Given this list of marker genes HPCAL4, PLEKHH3, RAB30, CAPNS1, NAT9, SCN5A, KCND1, ZNF436, MED25, PDAP1, RPL39, CTTNBP2NL, SEC24D, ARHGEF2, RPS6KA3 (NCBI Gene Id 6197), TREX1, GPR3, DHX40, JAK2, ABHD2, RPS6KA4, BRD2, RNF186, VIT, TGFBR2, ST6GALNAC5, RAB5A, SLC39A13, STAT6, RELA, AKAP1, TFE3, PA2G4, SLC25A23, SPRR1B, MMP7, PCDH9, FAM180A, NR1D1, RCAN2, PPP1R9B, COMMD10, S100A2, PADI3, PITPNC1, TMEM156, SGK3, MMP19, LINC03042, CHST1, TRAF3IP2, MAPK3, OMG, ESRRG, CLDN15, SH2D1B, AP2M1, ENO1, VEGFA, XPOT, EPHX4, TM4SF19, SV2A, TUBA4A, PTP4A1, DGKA, DLG4, GAPDH, TENT5A, YWHAB, AGPAT4, AP5B1, DES (NCBI Gene Id 497658), SLC4A11, PIP5K1A, MMP1, KRT17, ATP1B1, SH3RF1, SBSN, DDX17, CD244, AIG1, UBQLNL, KLK12, NECAB3, SAMD14, KCNK10, BMAL1, BUB3, PRPF38B, RIPK4, KLHL41, TRIM47, ENO3, HOXB4, DUSP14, AKR1B1, LORICRIN, MMP20, PRLHR, MPRIP, ANAPC10, MACF1, ZPBP2, ZNF362, CHMP4B, CIDEC, IGSF21, MAP7D1, KY, CRISP1, LRRC15, DYNC1LI1, ZNF277, ZHX3, ABCB6, PI15, MRPS23, SLC6A5, MSTN, C1orf210, NTN4, GABARAPL1 (GABA type A receptor associated protein like 1), DDR1, DIDO1, ZFYVE26, RELT (NCBI Gene Id 84957), C3AR1, STAT5B, MMP13, ADAMTS14, SEPTIN9, CSMD3, AMDHD2, NT5C1B, MED15, PFKFB3, KLF9, SEL1L3, ZBTB43, SMPX, NPPB, LYSMD2 (NCBI Gene Id 256586), SLC22A2 (NCBI Gene Id 6582), TIAL1, NDST4, CPNE1, RHOC, RTN3, NRXN3, CPSF7, FOSL1, SRPK2, ZNF516-DT, GJB3, RAB27B, ODF1, UBE2R2, AHI1, CAVIN1, MARK2, ADCY8, WDR81, DGKB, SSH2, CXCL14, KLHL7, NFE2L3, RUNDC3A, TBL1X, FGF13, LGI3, GIPC1, MYRF, CSF3, DSTN, KRT15, MMP3, TSSK6, RAB34 (NCBI Gene Id 83871), AP2A2, TLN2, SLC26A9, CCDC120 (coiled-coil domain containing 120), RIN2, HOXC10, NAPB, CDKN1A, FBXO30, KCNH2, MEF2C, HNRNPD, IGSF9, ATP6V0D2, CRYGS, GPR174, TAFA4, FADS3, WNT7B, CDKN2C, P2RX6, PPP1R3C, GGN, BNIP3, EEF1A1, JAZF1, THOC6, C2CD2L, ASPH, MIR22HG, TRIM8, SMARCA2, GLT8D2, LNX1, SLURP1 (secreted LY6/PLAUR domain containing 1), TTC1, IL7R (NCBI Gene Id 3575), IL21, CASKIN1 (NCBI Gene Id 57524), OSMR (oncostatin M receptor), MIR17HG, USP12, CHRM1, GTPBP2, COL7A1, SNCB, LINC01567, KRT8, LRRC8E, ENO2, C1orf21, VEZF1, PVALB, TMEM40, ATP6V1A, ACADVL, IQSEC1, PRKCG, METTL6, IPO11, MAP4, CHST9, TUBB4A, BEND6, PCDH17, DOK1, BTK, BDNF, SH3D21, ABCA2, ABI3, USP2, DCSTAMP, CST6, HS3ST2 (NCBI Gene Id 9956, heparan sulfate-glucosamine 3-sulfotransferase 2), SLC1A5, ARPP21, SGK1, EMP1, TGIF1, RHOG (NCBI Gene Id 391), YPEL5, PCSK1N, LRRFIP2, IL9, HSPB3, BMP2, PEX5, ZNF207, LNPEP, SOST, TOR4A, STARD13, PADI4, GPM6A, RTN1, MPV17, ARIH1, ISG20, TRIM25, PRKAG3, CDK14, PPARGC1A, BDKRB1, PRR7, NUDT11, PSMA1, CPNE8, NRXN1, ABHD4, RELL2, PHF23, PSTPIP1, FSIP2, UVRAG, VGF, MLEC, VAMP5, NDUFA13, RABGAP1L (NCBI Gene Id 9910), CSPG4, LAMA3, DTNB, SLC38A2, ARAP2, TPBG, FOXA1, KCNN4 (potassium calcium-activated channel subfamily N member 4), CREB5 (cAMP responsive element binding protein 5), CSN1S1, SLC35B1, CPA4, IVL, COL5A3, PPP2R2A, SFN, VEGFD, TOB1, ASXL1, PRDM1, HDAC3, CST7, RGS2, SLC10A2, SH3RF2, EPS8L3, FBXO44, STC1 (NCBI Gene Id 82914), MYH14 (NCBI Gene Id 79784), COL27A1, TGM7, DMKN, CHST4, TRIB1, GRIA1, WNT3, CA9, PTPRN, EBF2, AMY2B, VTCN1, KBTBD8, GPR141, NLGN3, LRRC32, ZNF385B, PROSER3, ABTB3, AK5, RBBP7 (NCBI Gene Id 5931), FGF9, ELK3, ADGRG1, NRAS, C22orf31, AQP5, TENM3-AS1, HMGA1 (high mobility group AT-hook 1), FAM81A, COQ8B, LMOD3, ELL, ONECUT2, ADRA1A, TAC1, CCDC14 (coiled-coil domain containing 14), ILDR2, DPYD, PIK3C2G, DSC2, LRRN3, LRRN4CL, VIL1, YWHAG, TNFRSF12A, EAF1, APOBR, SLC25A45, MARCHF1, SLC26A1, PAFAH1B1, SLITRK6, EDN3, PSMD12, GPR158 (G protein-coupled receptor 158), CACNA1A, RUNX1T1, CD68, CXCR5 (C-X-C motif chemokine receptor 5), CLDN4, PEA15, ADAP2, CLDN9 (claudin 9), ADAMTS6, PDE4D, GAB2, AGBL5, MYBPH, PERP, GNGT2, BDKRB2, USP3, HARBI1, PPP1R15A, AKT3, ZRSR2, SRSF2, GDNF, BLMH, KRT16, HNF1A, PSMD7, FOXN1, MECOM, PKNOX2, TSR1, CCDC141, DMPK, TMEM14B, PKN1, ASS1, SERPINB2, REEP4, IDS, FAM91A1, HILPDA, ARF1, REPS1, GASK1B, PPP2CA, DRP2, BBLN, VAPA, SLC16A6, FBXO24, MIDEAS, CIMAP2, CLDN16 (NCBI Gene Id 107986170), SLC6A14, LONRF3, EFNA1, PDZD9, MAMDC2, SLC38A6, SFR1, ADGRF2P, TCF12, CAMK4, CSRNP1, MDM2, LINC02694, CYFIP1, VAX1, TSKU, ARHGAP8, PLA2G4F, SNCG, SPATS2, TLL1, VCL, HDAC9, CALB2, GASAL1, DTNA, RNF44 (NCBI Gene Id 260352), TMEM50B, NEFH, TFF1, FLI1 (NCBI Gene Id 2313), PRSS36, STRN3, ATG13, PSMD1, AIF1L, ETV5, ZBTB41, ESR1, MYB, DNAJC5B, GPR87, PROCR, FABP4, LGALS7, MPP3, GTF2F2, CNOT6L, G0S2, KLHL40, BTG3, MASP1, WNT6, F3, KCNQ1DN, PRDM12, PLAU, KRT13, CNGB3 (cyclic nucleotide gated channel subunit beta 3), AEBP1, KDM5C, KRT25, APP, FST, XYLT1 (NCBI Gene Id 64131), MYL6B, PSMD4, MMP12, TRAPPC3, HSPB7, NCS1, SLC6A10P, POLD4, EML3, TAGLN2, UCN2, LENEP, CA7, AXIN2, HAUS1, EPB41L1, ZNFX1, PDE6H, PSMA5, KLHL13, S100A5, NCDN, SLC9A8, SH2D3A, RNF144B, ARHGAP32, C1orf220, CAPN12, MYLK, ELAVL2, LMO4, FCHSD1, FGF11, CNTNAP2, LTB4R2, MSI1 (musashi RNA binding protein 1), BAG2, PDGFRA, DIRAS1, CYTOR, FAM20A, SLC35F6, DUSP13B, CCL27, ZNF827, TRIM9 (tripartite motif containing 9), PRX, TFB1M, POLR3E, PTMS, NRN1L, FGF1, ABCD1, SERPINB5, DYNC1H1, SLC6A12, ATP6V1C1, CYRIA, MCTP1, GALNT13, MMP9, C15orf39, ANXA7, KRT14, EPHA2, TBC1D10B, TNIP3, ATF4, PLCD1, IL11, PTH1R, NRDC, GFI1, SCRN1 (NCBI Gene Id 9805), WDFY4, DCT, FBXO2, MAPK12, SMTN, LGALS3 (NCBI Gene Id 81625), TAF15, THPO, SKIDA1, RYBP, H3-3B, CEP135, DLX1, SYT8, LGALS1, GADD45G, YIF1A, ITGAX, SLC25A24, TFEB, PLA2G2E, SHOX2, FAM184A, NCAN, CLC, ASB5, MME, MCF2L, GFRA1, PKN3, GIT1, ATXN7L2, RBM39, RXFP2, PACSIN3, HBEGF, CTNNAL1, ALOXE3, CTHRC1, DCTN2, TRAF3, ZFAND5, PPP2CB, COA3, LPAR4, SNAP25, NUDT10, GPAT3, TP63, CCR9, MAST2, RHBDF1 (NCBI Gene Id 64733), PSMD2, ELOVL1, PCYT2, STOML2, LRRTM3, DSC3, CLVS1, MAP4K5, ATP5F1A, LINC02908, FURIN, LINC00649, EPN3, SERPINB7, GSE1, SGMS1, GJA1, WDFY3-AS2, NUAK1, TRPV3, DOCK4, SPRR1A, SSBP3, CRYBA2, PALS1, ABCF3, PODN, RNF182, SPATA16, BLOC1S1, PIANP, CEPT1, FLNC, MMRN2, KPNA4, BAZ2A, PSMA3 (proteasome 20S subunit alpha 3), FERMT3, NOTCH4, SYT10, CLDN17, STX1A, ZFYVE9, RIN1, TPM2, AMBN, PKM, PLCD4 (phospholipase C delta 4), HCFC1R1, KCNK1, UBE3A (NCBI Gene Id 7337), SIPA1L1 (NCBI Gene Id 283567), ARX, MRGPRF, RNF34, ECM1, ZNF771, GADD45B, ITPKC, WNT8B, PRDM13, RASEF, TMPRSS11F, CSF1R, RB1CC1, ADRA2C, NASP, CXCL5, HS3ST3B1, LRCH4, ZFP28, RNF145, HOXA11, KRTAP13-2, SHROOM1, RELCH, POPDC3, DNAI3, GPR55, AVP, AGR2, NDP, LAT (linker for activation of T cells), MECP2, SNX10, TTLL6, NME1, SLC9A7, NEK6, PKP3, EEF1A2, SLC11A1, OTUB2, STK40, CAVIN3, ODAPH, PFN1, SLC38A3 (NCBI Gene Id 10991), SCEL, HEPH, TMEM134, CAPN6, PLEC, KRT10-AS1, NAA50, TAB2, BARHL2, STAT1, NPHP4, NR0B2, SSTR2, C19orf33, PFKFB2, ADAMTSL1, SAT1, CAB39 (calcium binding protein 39), SERTAD1, TOR1AIP2, HSPA9, PAWR, XIRP1, KRT78, NRP2, NFATC4, LMNA, MDFI, PTPRR (NCBI Gene Id 5801), TRIM29, FKBP5, FBXW11, CD151, LAMC1, WASF2, SDCBP, CACUL1, ARPC5L, HSPG2, BCL2L10, COL1A1, RHO, DCLK1, LRRC2, TTLL7, LUC7L, TGM1, DTX2, GSDME, GIT2, ZNF503, UBA1, RASL11B, GJB5, KRT19, BMAL2, MAPK10, SYT2, LAMB3, IL22RA1, PDLIM2, YAE1, ACSL4, SDHAF2, GEN1, PROK2, CNTF, RIMS1, STARD8, SPTBN2, GPNMB, LOXL4, NPEPPS, SUPT4H1, ZFP36L1, VAT1, OSBP, SLC38A1, SHC3, LRP1, EMP3, GZMB, DMD, ALDOA, PCSK6 (NCBI Gene Id 5046), NEFM, CLCN5, KDM3A, SPTLC2, ROCK2, LPP, ETFB, SERINC2, CDH23, SYTL1, PDE1B, BCAS3 (NCBI Gene Id 89751), SFTPC, AKT1S1, FGF10, ADM, GJA5, RERE, PLP2, RBPJ, TMEM43, EPHA1, LRSAM1, NMT1, SPINK6, TXLNG (NCBI Gene Id 55787), WDFY3, SPRED1, HID1, S1PR2, ROM1, TSPEAR, TNKS2, NRG1, SQSTM1, F2RL2, RCAN1, SEMA6B, TFPI2, ITGA2, EHF, IL16, TYSND1, VPS25, IGSF8, PSMD11, HTR1D, DLL1, HCN3, RTL9, IGSF3, SYNGR1, DYSF, CDH5, TRIM54, TMEM104, RIT1, CMAS, S100A10, ITGB4, PRF1, IL27, FAM120C, LYVE1, UBALD2, NPTN, ZC2HC1C, ANK3, BMP5, SEPTIN4, IQCF1, IGFBP6, SCOC, SVIL, SLC22A18AS, SNPH, SPR, MAPRE3, DCX, GAST, GLI2, MAP2, VWA7, ATL1, LDB3, SRPX2, LY6D, UBE2E3, CLIC1, PPP2R2C, EPHB2, DENND1B, PRSS22, CHCHD4, PHLDB3, PIM1, KIRREL3, DHRS3, EN1, PAF1, EYA1, SLC5A2, STK10, IRAK1, MAGED1, GPX1, CCR7, HSD3B7, IL1R1, PMP22, SYP, OTP, SLC22A18, N4BP1, ETV4, RBKS, GPC3, SPAG9, UBE2C, COBL, ADGRG4, GNAI1, GFAP, HSPB6, TLK2, PPP1R8, LRP1B, LY6G6D, ATP11C, DCAKD, PRRG4, FAP, LYNX1, BCL9L, ZBTB32, RAB3D, FBP2, BICDL1, ALS2, SPTA1 (spectrin alpha, erythrocytic 1), MPZL2 (myelin protein zero like 2), BABAM2, MT3, AKIRIN2, ACTN4, GIGYF2, NCOA4, RHOQ, UBALD1, VASN, DDIT3, TNFRSF9, APOBEC1, RGS3, NRIP3, ABCE1, TBL1Y, GPRIN3, ANKRD22, IL23A, ANGPTL4 (NCBI Gene Id 93954), ANKRD40, TOR1AIP1, CRNN, MIER1, DYRK1A, AP4S1, TINAGL1, OMD, TLX2, CKMT1B, C7orf33, NFRKB, TMEM95, CHP1, SLC24A4, EIF3J, BACH1, ORAI1, LAMC2, SHISA5 (NCBI Gene Id 51246), TGM3, FBRS, ZMAT5, GKN1, TEX19, PMCH, PTPRU, RPL23A, COL5A2, STX11, BUD31, KLF5, TMCC1, LY6G6C, TMEM151A, TUBA1C (tubulin alpha 1c), RUNX1, YWHAZ, RTN4, VDR, FHL3, FEZF2, ITM2B, LTBP3, PHLDA2, PPP2R2B, OR2F1, ANKRD28, SLC25A51, FGF12, ZNF654, ACSL3, RPS20, PAPPA, SPARC (secreted protein acidic and cysteine rich), MICALL1, TPP1, MARK1, NEBL, CNTD1, SMC6, PAK6, TNXB, UBE2D1, PIP4K2C, TBXAS1, KRT86, GADD45A, TBC1D17, PROM2, NLK, SLCO5A1, CRACDL, THRB, EIF4G1, CSTPP1, SYN1, COL16A1, FAM135B, NSD1, CLRN1 (NCBI Gene Id 7401), PSME4, ST18, STC2 (stanniocalcin 2), SLC9A1, SGCZ, PDZRN4, CASK, XDH, POU2AF1, ELOVL4, C1QTNF8, SFTPD, IL10, FAM117A, ARID3B, THBS1, ACP3, FRMD5, KMT2C, CCDC50, ZFR (zinc finger RNA binding protein), KCNA2, CSNK1A1, ATP6V1H, HCLS1, S1PR1, NR1I3 (NCBI Gene Id 9970), GAPDHS, SEC16B, DIAPH1, CLSTN3, SYNPO, SCAMP1, EXD1, USP13, IL6, PDGFRB, SLC7A8, NPFFR1, ADAM15 (ADAM metallopeptidase domain 15), CDC14A, RASSF8, MNT (MAX network transcriptional repressor), NDRG2, SLC35E4, ANGPT1, PHF3, CPA6, CAMKK1, MITF, SEMA3B, STMN2, CIRBP, TNRC6A, MYOZ2, TUBA4B, IL24, ASCL2, NEK8, VAMP2, MGST3, RGS8, CRB3, UBQLN1, GPR183, HK3, DUSP22, LGALSL, ADGRL2, GSTP1, TENT5B, TINAG, MAP3K6, VASP, PLBD2, CBFA2T2, ATP6V0A1, OLR1, SUOX, ALS2CL, MAP1A, KCNH3, RBP4, IL1RN, ATP2A2, here is a description of the gene set: Human Gene Set: TGANTCA_AP1_C Comprehensive identification of all functional elements encoded in the human genome is a fundamental need in biomedical research. Here, we present a comparative analysis of the human, mouse, rat and dog genomes to create a systematic catalogue of common regulatory motifs in promoters and 3' untranslated regions (3' UTRs). The promoter analysis yields 174 candidate motifs, including most previously known transcription-factor binding sites and 105 new motifs. The 3'-UTR analysis yields 106 motifs likely to be involved in post-transcriptional regulation. Nearly one-half are associated with microRNAs (miRNAs), leading to the discovery of many new miRNA genes and their likely target genes. Our results suggest that previous estimates of the number of human miRNA genes were low, and that miRNAs regulate at least 20% of human genes. The overall results provide a systematic view of gene regulation in the human, which will be refined as additional mammalian genomes become available. Genes having at least one occurrence of the highly conserved motif M7 TGANTCA in the regions spanning 4 kb centered on their transcription starting sites. This matches the JUN transcription factor binding site V$AP1_C (v7.4 TRANSFAC). studied in species Homo sapiens from publication Xie X, Lu J, Kulbokas EJ, Golub TR, Mootha V, Lindblad-Toh K, Lander ES, Kellis M (PMID 15735639)